The following is a description of a gene set: species: Mus musculus The clustering together and adhesion of initially separate cells to form an aggregate. Examples include the clustering of unicellular organisms or blood cells in suspension and the condensation of mesenchymal cells during cartilage formation. Mouse Gene Set: GOBP_CELL_AGGREGATION, and this is the list of marker genes: Uncx, Myf5, Sox6, Ltf, Tgfb2, Fgf6, Thra, Mpz, Sox5, Bpifa5, Col11a1, Wnt7a, Bpifa1, Mycn, Fgf4, Otor, Col2a1, Tmigd1, Ccn2, Bmpr1b, Mapk14, Sulf1, Acan, Ror2, Sox9, Pkd1, Barx2